Given this list of marker genes SSR3, ITFG2, EIF2AK3, LUC7L2, FANCD2, P4HTM, KDM1A, SLC25A25-AS1, SRSF4, PRKCZ, SEL1L3, SMIM10L2B-AS1, ADCY10P1, MTERF3, LINC00342, EWSR1, ARGLU1, ETV7, MARS1, RBM34, MEN1, DICER1-AS1, CHD6, ZNF891, DNAAF8, ENOSF1, ILKAP, SCARNA15, LDHB, AMN1, IGLV1-44, PABPC1L, COBLL1, COX19, SLC12A6, COQ3, JCHAIN, PDK1, TMEM63A, GABPB1-AS1, HMGXB3, HSP90B1, DARS1, IGKV3-20, NPIPA1, RPLP2, MBD1, TP53INP1, SRSF1, NSUN5P1, CCNL2, ZNF7, AKT2 (AKT serine/threonine kinase 2), MPHOSPH9, GTPBP3, DHFR2, IGLV2-23, FOXJ3, ADAM19, TNFRSF25, CAV1 (NCBI Gene Id 857), GON4L, NOL4L, GGH, SEC11C, SNRNP70, RNASEH1, PTCD3, SLC1A4, POU2AF1, KLHL14, GTF3C2, PTTG1, ENTPD4, RASGRP3, HDDC3, DNAJB11, MIATNB, ECHDC2, STMN3, CEP43, IGLV6-57, TOP6BL, OGT, LRRC74A, UBQLNL, QSOX2, PRSS33 (NCBI Gene Id 260429), LIME1, SYMPK, TRIM66, NODAL, UVSSA, NPHP3, HECTD1, GPLD1, TUBGCP5, ZBTB25 (zinc finger and BTB domain containing 25), SOX6, PRDX4, IGHG1, NSUN5, METTL3, SNRNP200, TRIM73, PPIB, TNFRSF13B, MCM7, CSAD, SPG7, PRKN, PAXIP1-DT, HLA-DQB2, XBP1, STX16, CXorf65, LINC02245, ADAT2, HERC2, IGKV1D-13, C2orf80, GLDC, GARIN5A, USP45, BMS1P20, ATCAY, ORC6, NSUN5P2, PDE1C, DENND5B, EDEM1, GTF3C4, ASXL1, MZB1, DGKD, SLC25A28, GYS1, HAPLN3, UBR5, OLFM4, ZNF500, ISG20, ZNF274, PDIA4, VN1R1, MSTO1, MON1A, CDK5RAP1 (CDK5 regulatory subunit associated protein 1), IGLJ3, SLC7A6, TNFRSF17, SPATS2, GRAMD1A, FAM193B, DGKA, CABIN1, FOSL2-AS1, ZNF791, PKD1P1, TRAF1, BTAF1, MAGED1, PDIA5, CD38, GLCCI1, DDX51, IGLV3-19, UBAP2, ADGRG3, STARD5, ITM2C, ZNF506, TPD52, CREBZF, PKHD1L1, MOXD1 (monooxygenase DBH like 1), LTBP3, VAMP1, MTRF1, SCHIP1, FKBP11, MSI2, ING5, PART1, TCF3, SLC25A45, ZBTB40, GUSBP11, ZNF529, CYP4F3 (NCBI Gene Id 89256), PAN2, here is a description of the gene set: Genes down-regulated in comparison of peripheral blood mononuclear cells (PBMC) from TIV influenza vaccinee at day 3 post-vaccination versus those at day 7 post-vaccination. Systems vaccinology has emerged as an interdisciplinary field that combines systems wide measurements and network and predictive modeling applied to vaccinology. Here we used the systems vaccinology approach to study the molecular mechanisms underlying th from publication Nakaya HI, Wrammert J, Lee EK, Racioppi L, Marie-Kunze S, Haining WN, Means AR, Kasturi SP, Khan N, Li GM, McCausland M, Kanchan V, Kokko KE, Li S, Elbein R, Mehta AK, Aderem A, Subbarao K, Ahmed R, Pulendran B (PMID 21743478) Human Gene Set: GSE29617_DAY3_VS_DAY7_TIV_FLU_VACCINE_PBMC_2008_DN species: Homo sapiens